The following is a description of a gene set: Metabolism of steroid hormones species: Homo sapiens Human Gene Set: REACTOME_METABOLISM_OF_STEROID_HORMONES, and this is the list of marker genes: HSD3B1, SRD5A1, HSD17B11, CYP11B1, CYP19A1 (cytochrome P450 family 19 subfamily A member 1), FDXR, STARD6, CYP21A2 (NCBI Gene Id 1589), TSPOAP1, SERPINA6, HSD17B14, STAR, POMC, FDX1, LHB (NCBI Gene Id 3972), AKR1B1, STARD3 (StAR related lipid transfer domain containing 3), TSPO, STS, SRD5A3, FDX2, HSD11B1, CGA, AKR1B15, CYP11A1, CYP17A1, HSD17B3, HSD11B2, HSD17B1, HSD17B12, HSD3B2, STARD4, CYP11B2, STARD3NL, HSD17B2, SRD5A2